The following is a description of a gene set: Mouse Gene Set: GOBP_RESPONSE_TO_ETHER Any process that results in a change in state or activity of a cell or an organism (in terms of movement, secretion, enzyme production, gene expression, etc.) as a result of a ether stimulus. studied in species Mus musculus, and this is the list of marker genes: Oxt (NCBI Gene Id 18429), Golph3 (NCBI Gene Id 93791), Nanog, Larp1, Zc3h12a, Cyp1a1, Cav3, Abcb4, Foxp1, Ifitm5, Plcb1, Crh, Mdm2, Nfatc4, Hnf1a, Lipa, Foxp3, Zfp683, Hnrnpd, Arpc2, Ptafr, Plcg1, Cdk4, Ucp3, Adm, Th